The following is a description of a gene set: Human Gene Set: KEGG_MEDICUS_REFERENCE_TNF_P38_SIGNALING_PATHWAY studied in species Homo sapiens Pathway Definition from KEGG: TNF -> TNFRSF1A -> (RIPK1+TRADD+TRAF2/5) -> (TAK1+TAB1/2) -> MKK3/6 -> MAPK14 -> MSK1/2 -> CREB TNF-p38 signaling pathway. Pathway ID: N00444. Pathway type: Reference. Pathway class: nt06516 TNF signaling., and this is the list of marker genes: TRAF2, TNF, MAP2K3, MAP3K7, ATF6B, MAPK14, ATF2, RPS6KA5, CREB1, CREB5, TRAF5, CREB3, TAB2, TNFRSF1A, CREB3L4, MAP2K6, TRADD, RIPK1, CREB3L3, RPS6KA4, CREB3L2, ATF4, CREB3L1, TAB1